Given this list of marker genes UPP2, SCAPER, ZDHHC12, ST8SIA6, ACTN1, SH3BP1, UBA7, NUP160, RINL, CARNS1, SLC25A25, AKAP10, CPNE4, STK32B, DUS3L, RGL2, MIA, FAM234B, SKA2, APBB1IP, RPL4, CD68, PECAM1, TPMT, SUPT5H, CACNG8, LOXL4, ISG20L2, RTN1, AKAP6, MARVELD3, ADORA2A, SLC25A30, TGM2, ARFIP2, ADAMTS2, DDI2, NFAM1, DCAF8, SIX5, WNT9B, DRD2, PAX4, XK, DNAJC22, KHNYN, FAM111A, PPP1R37, ZNF445, ARHGAP39, ARHGDIB, BCAS1, PIP4P1, TSEN34 (NCBI Gene Id 79042), TMC4, CEP164, SMG1, RAD1, GABRP, RAB21, FRMPD3, DUSP7, TPCN2, ERLIN2, SLC38A1, THUMPD2, NPL, CYRIA, TMEM150C, COQ8A, DYNLT2B (NCBI Gene Id 255758), THEMIS, TMEM52B, ZNF217, ARHGAP9, SLX4, UBN1, PIGZ, TRAPPC6B, CCNJL, PTCH1, ZNF444, RASAL1, UBR2, BANK1, WDR11, PEX11B, FGFR2, SH2D4A, KCTD8, MDH2, CTSZ, SLC4A4, CHL1, SNX10, CSNK2B, FNTB, APOBEC3B, GJB1, PDE10A, IZUMO4, ENTPD8, UPK1B, DDX19A, SLC20A2, TNFRSF4, EIF4B, HDAC7, TSPAN9, GALNT4, DNAJC28, RARG, HEMK1 (NCBI Gene Id 51409), EPHX2, RALY, NCALD, SNPH, BCOR, FNDC11, DNM2, BCL11A, MIIP, PSD4, LBR, EPCIP, KRT32, PLEKHA3, TRAF2, SLC44A2 (NCBI Gene Id 57368), SIRPB1, ACAP1, DBNL, RGS12, GLUD1, ACTR2, DOK7, MYLK3, ZNF3, CYLD, SVEP1, ARMH3, KCNK16, TNS1, EML5, ELL, KIF15, SPINT1, CCAR2, CDKN2B, COL6A2, LENG8, ANKS1A, TRARG1, CMIP, MYO9B, IL36G, SAFB2, NR1H3, DDX11, HDAC10, SYMPK, CIITA, GFPT1, COLCA1, DISP2, LSM2, ABRAXAS1, SERPINI1, CLASRP, GRM4, PCYT1B, TP53RK, MAPK8IP3, UCP3, ST3GAL2, AHSG, ICOS, GPBP1L1, JAK3, ABI3, N4BP2L1, CYP2A6, TRAPPC14, CYBA, COL14A1, AKR7A2, PRELP, CYB5R3, LRRC72, XPNPEP2, COL12A1, DNA2, LIME1, IL4I1, SETD5, CAPZB, EFHD2, DCBLD1, TMEM74, RANBP3L, here is a description of the gene set: studied in species Homo sapiens Human Gene Set: GSE29164_DAY3_VS_DAY7_CD8_TCELL_TREATED_MELANOMA_UP from publication Kerkar SP, Goldszmid RS, Muranski P, Chinnasamy D, Yu Z, Reger RN, Leonardi AJ, Morgan RA, Wang E, Marincola FM, Trinchieri G, Rosenberg SA, Restifo NP (PMID 22056381) Genes up-regulated in mock treatment during adoptive transfer therapy of B16 melanoma: day 3 versus day 7. Myeloid-derived cells comprising the tumor stroma represent a heterogeneous population of cells critical to the structure, function and growth of established cancers. We have recently found that engineering tumor-specific CD8+ T cells to secrete IL-12 (IL-12TD) can lead to striking improvements in T-cell activity against established melanomas in murine models. Surprisingly, IL-12-dependent enhancement of CD8+ T-cell anti-tumor function did not occur through direct ligation of receptors on lymphocytes or NK cells. Instead, IL-12 sensitized host bone marrow-derived tumor-stromal cells, partly through interferon-gamma, to indirectly enhance the effects of adoptively-transferred T cells. Direct presentation of antigen by tumor was not necessary, but MHC class I expression on endogenous cells was essential for IL-12 mediated anti-tumor enhancements. Upon successful treatment with IL-12TD cells, we observed the selective elimination of tumor-infiltrating CD11b+ F4/80+ macrophages, CD11b+/ClassII+/CD11c+ dendritic cells and CD11b+/Ly6C+/Ly6G- but not CD11b+/Ly6C+/Ly6G+ myeloid-derived suppressor cells within regressing lesions. These results are consistent with a model whereby IL-12 triggers the maturation of myeloid-derived cells into competent antigen cross-presenting cells. Licensed recognition of these antigens by effector T cells may in turn trigger the collapse of the tumor stroma and aid in the regression of large vascularized lesions.